Given this list of marker genes KCND3, CALM2, CACNA1C, GPC3, GNB2, KCNE2, TBX5, GMPPB, DPAGT1, AKAP9, KCNH2, ANK2, SCN10A, CACNB2, CACNA1S, TRDN, SVIL, KCNQ1, FBN1, ALPK3, CLCNKB, CALM1, SCN5A, BPTF, TECRL, CAVIN1, CDC73, TRPM4, GPC4, PSMD12, SNTA1, ACADVL, HADH, DNAJC19, GABRA3, SLC4A3, CACNA2D1, KCNE1, MECP2, SLC12A3, KCNJ18 (NCBI Gene Id 100134444), TANGO2, CAV3, RYR1, TNNI3K, NOS1AP, PHOX2B, CDKN2C, KCNA5, HCN4, CDKN1A, ALG10B, KCNJ2, LTBP2, CALM3, ADAMTS10, TNNT2, SCN4B, ADAMTS17, FLNC, LMNA, KCNJ5, MEN1, SLC6A8, STX16, GNAS (GNAS complex locus), CDKN2B, CDKN1B, SRY, here is a description of the gene set: Abnormal QT interval Any anomaly of the time interval between the start of the Q wave and the end of the T wave as measured by the electrocardiogram (EKG). studied in species Homo sapiens Human Gene Set: HP_ABNORMAL_QT_INTERVAL